The following is a description of a gene set: species: Homo sapiens The series of molecular signals initiated by glutamate binding to an NMDA-selective glutamate receptor on the surface of the target cell, followed by the movement of ions through a channel in the receptor complex, and ending with the regulation of a downstream cellular process, e.g. transcription. Human Gene Set: GOBP_NMDA_SELECTIVE_GLUTAMATE_RECEPTOR_SIGNALING_PATHWAY, and this is the list of marker genes: APP, NRXN1, MEF2C, C14orf28, NLGN1, CAPN1, DLG4